The following is a description of a gene set: species: Mus musculus Any process that results in a change in state or activity of a cell or an organism (in terms of movement, secretion, enzyme production, gene expression, etc.) as a result of a dexamethasone stimulus. Mouse Gene Set: GOBP_RESPONSE_TO_DEXAMETHASONE, and this is the list of marker genes: Ucp2, Smyd3, Gjb2, Tgfb1, Ghsr, Ep300, Eif4e, Pck2, Gad2, Mir155, Ddit4, Hnrnpu (heterogeneous nuclear ribonucleoprotein U), Eif4ebp1, Cldn1, Crh, Bmi1, Ass1, Mettl21c, Fech, Bmp4, Casp9, Gba1, Cps1, Jak2, Ccl2, Mir21a, Foxo1, Edn1, Tat, Fbxo32, Tbx2, Aqp1, Hdac6, Star, Abcb1a, Serpinf1, Atp5f1a, Gdnf, Egfr, Pappa, Agtr2, Cyp1b1, Foxo3, Axin2, Ptafr, Nr3c1, Pik3ca, Ifnb1, Ace, Epo, Trim63, Rps6kb1, Por, Pcna, Agtr1a (angiotensin II receptor, type 1a), Mstn, Pck1, Agtr1b